The following is a description of a gene set: species: Homo sapiens Human Gene Set: GOMF_ACTIVIN_RECEPTOR_BINDING Binding to an activin receptor., and this is the list of marker genes: INHBA, CFC1, CRIPTO, CFC1B, MAGI2 (membrane associated guanylate kinase, WW and PDZ domain containing 2), FKBP1A, NODAL, SMURF1, SMAD7, SMAD6, CRIPTO3